The following is a description of a gene set: Mouse Gene Set: GOBP_NEUROTRANSMITTER_RECEPTOR_INTERNALIZATION species: Mus musculus A receptor-mediated endocytosis process that results in the internalization of a neurotransmitter receptor., and this is the list of marker genes: Rab11fip5, Iqsec1, Ap2m1, Tspan7, Nedd4, Itgb3, Rabep1, Cblb, Rnf220, Pip5k1c, Synj1, Nedd4l, Ncdn, Ap2a2, Sirt2, Usp46 (ubiquitin specific peptidase 46), Susd4, Scrib, Akap5, Lpar1, Ap3m1, Atad1, Rnf216, Pick1, Ophn1, Ppp3r1, Numb, Tamalin, Vac14, Gsg1l, Arc, Ap2b1, Caly, Ap2a1, Eps15, Sh3glb2, Hap1, Efnb2, Mdm2, Hpca, Lrp1, Nrg1, Rala, Hip1, Drd4, Dnm3, Pacsin1, Syt17, Myo6 (myosin VI), Drd3, Ap2s1